The following is a description of a gene set: from publication Su Z, Ho JWK, Yau RCH, Lam YL, Shek TWH, Yeung MCF, Chen H, Oreffo ROC, Cheah KSE, Cheung KSC (PMID 38267611) Identified by co-expression of COLIA1/Collagen I and gene markers (e.g., COL2A1/Collagen II, COL9A1, and HAPLNI) that were enriched in chondrogenic characteristics. The transformation of benign lesions to malignant tumours is a crucial aspect of understanding chondrosarcomas, which are malignant cartilage tumours that could develop from benign chondroid lesions. However, the process of malignant transformation for chondroid lesions remains poorly understood, and no reliable markers are available to aid clinical decision-making. To address this issue, we conducted a study analysing 11 primary cartilage tumours and controls using single-cell RNA sequencing. By creating a single-cell atlas, we were able to identify the role of endoplasmic reticulum (ER) stress in the malignant transformation of conventional central chondrosarcomas (CCCS). Our research revealed that lower levels of ER stress promote chondrosarcoma growth in a patient-derived xenograft mouse model, while intensive ER stress reduces primary chondrosarcoma cell viability. Furthermore, we discovered that the NF-?B pathway alleviates ER stress-induced apoptosis during chondrosarcoma progression. Our single-cell signatures and large public data support the use of key ER stress regulators, such as DNA Damage Inducible Transcript 3 (DDIT3; also known as CHOP), as malignant markers for overall patient survival. Ultimately, our study highlights the significant role that ER stress plays in the malignant transformation of cartilaginous tumours and provides a valuable resource for future diagnostic markers and therapeutic strategies. studied in species Homo sapiens Human Gene Set: SU_HO_CONV_CENT_CHONDROSARCOMA_STROMAL_C3_FIBROCARTILAGE_CHONDROCYTE, and this is the list of marker genes: S100A1, HAPLN1, ANGPTL2, RARG, SCIN, EPYC, EPS8L2, SDF4, SERPINA1, ADK (adenosine kinase), PPP1R3C, TOMM7, ESPN, CHADL, FXYD6, RPL4, DOK1 (docking protein 1), PAPSS1, FBXO2, NGEF, CKB, TPD52L1, CPXM2, NXPH4, PDCD6, COL9A2, COL2A1, TSC22D4, PLD3, MDFI, P4HB, CIRBP, TUBB4B, AVPI1, CREB3L2, PDLIM4, RPL15, IGFBP3, TUBB2B, OBSL1, PLOD2, P4HA1, PPDPF (NCBI Gene Id 79144), PAPSS2, OS9, CHST3, GPRC5C, PFKP, SPINT2, COL9A3, XYLT1, BHLHE41, PGM1, CRYAB, ANGPTL4, FRZB, SNORC, CA9, P4HA2, PDE4DIP, SMIM5, GAPDH, APLN, SLC14A1, MAGED2, CNMD, COL11A1, SLC25A37, NDUFA4L2, LOXL3, COL9A1